Given this list of marker genes DNAJC5, SYT1, STX1A, CPLX1, RIMS1, SLC6A1, SLC32A1, HSPA8, SLC6A11, RAB3A, SNAP25, GAD1, SLC6A13, ABAT, STXBP1, GAD2, VAMP2, SLC6A12, ALDH5A1, here is a description of the gene set: part of: Neurotransmitter release cycle Reactome Pathway: GABA synthesis, release, reuptake and degradation species: Homo sapiens GABA is a major inhibitory neurotransmitter in the mammalian central nervous system. GABA modulates neuronal excitability throughout the nervous system. Disruption of GABA neurotransmission leads to many neurological diseases including epilepsy and a general anxiety disorder. GABA is synthesized by two distinct enzymes GAD67 and GAD65 that differ in their cellular localization, functional properties and co-factor requirements. GABA synthesized by GAD65 is used for neurotransmission whereas GABA synthesized by GAD67 is used for processes other than neurotransmission such as synaptogenesis and protection against neuronal injury. GABA is loaded into synaptic vesicle with the help of vesicular inhibitory amino acid transporter or VGAT. GAD65 and VGAT are functionally linked at the synaptic vesicle membrane and GABA synthesized by GAD65 is preferentially loaded into the synaptic vesicle over GABA synthesized in cytoplasm by GAD67.The GABA loaded synaptic vesicles are docked at the plasma membrane with the help of the SNARE complexes and primed by interplay between various proteins including Munc18, complexin etc. Release of GABA loaded synaptic vesicle is initiated by the arrival of action potential at the presynaptic bouton and opening of N or P/Q voltage gated Ca2+ channels. Ca2+ influx results in Ca2+ binding by synaptobrevin, which is a part of the SNARE complex that also includes SNAP25 and syntaxin, leading to synaptic vesicle fusion. Release of GABA in the synaptic cleft leads to binding of GABA by the GABA receptors and post ligand binding events.